Given this list of marker genes PSMC6, AKT3, HDAC3, MIR17, PSMB6, MIR26A1, CSNK2A1, MIR19B2, PSMD14, TNKS2, LAMTOR4, PSMA2 (NCBI Gene Id 5683), MIR22, MTA1, EGR1, MAPK1, HDAC1, PSMD3, PSMC1, CHD3, CBX8 (NCBI Gene Id 63441), PSMB3, RRAGB, GATAD2B (GATA zinc finger domain containing 2B), USP13, JUN, MECOM, TNRC6B, RBBP7, CSNK2B, PSMA4, PSMB7, PSMB2, PSMA1, BMI1, PSMB5, PSMD12, AGO4, PHC1 (NCBI Gene Id 283368), CBX4, PSMA7, RBBP4, PPARG, LAMTOR1, PHC3, CSNK2A2, WWP2, MTOR, CBX6, PSMA3, MIR19B1, TP53, MKRN1, MIR25, AGO1, XIAP, SEM1, PSMA6 (proteasome 20S subunit alpha 6), MOV10 (NCBI Gene Id 57723), MIR106B, UBB, TNKS, ATN1, PSMC2, MIR214, RPTOR, MTA2, PSMA5, PSMD13, SLC38A9, AGO3, STUB1, PML, PSMD7, ATF2, EED, SALL4, PSMC5, MIR93, USP7, GATAD2A, PSMD2, CHD4, MLST8, SCMH1, PREX2 (phosphatidylinositol-3,4,5-trisphosphate dependent Rac exchange factor 2), PSMD6, RHEB, PTENP1, MBD3, REST, MTA3, MAF1, NEDD4, NR2E1, LAMTOR5, SUZ12, SNAI2, MIR106A, HDAC5, PSMC3, MIR20A, TNRC6A, PSMB1, LAMTOR3, TRIM27, AGO2, VAPA, RNF2, AKT1, MIR20B, RRAGD, FRK, AKT2, CNOT6L, RING1, PSMB4, PSMD8, CBX2, MIR19A, PSMC4, UBC, RRAGC, PHC2, ADRM1, RCOR1, TNRC6C, LAMTOR2, MIR26A2, MIR205, MIR21, EZH2, MAPK3, RPS27A, PSMD1, RNF146, PTEN, OTUD3, PSMD11, UBA52, HDAC2, RRAGA, KDM1A, SNAI1, HDAC7, here is a description of the gene set: PTEN is regulated at the level of gene transcription, mRNA translation, localization and protein stability.<p>Transcription of the PTEN gene is regulated at multiple levels. Epigenetic repression involves the recruitment of Mi-2/NuRD upon SALL4 binding to the PTEN promoter or EVI1-mediated recruitment of the polycomb repressor complex (PRC) to the PTEN promoter. Transcriptional regulation is also elicited by negative regulators, including NR2E1:ATN1 (atrophin-1) complex, JUN (c-Jun), SNAIL and SLUG and positive regulators such as TP53 (p53), MAF1, ATF2, EGR1 or PPARG.<p>MicroRNAs miR-26A1, miR-26A2, miR-22, miR-25, miR-302, miR-214, miR-17-5p, miR-19 and miR-205 bind PTEN mRNA and inhibit its translation into protein. These microRNAs are altered in cancer and can account for changes in PTEN levels. In addition, coding and non-coding RNAs can prevent microRNAs from binding to PTEN mRNA. These RNAs are termed competing endogenous RNAs or ceRNAs. Transcripts of the pseudogene PTENP1 and mRNAs transcribed from SERINC1, VAPA and CNOT6L genes exhibit this activity (Poliseno, Salmena, Zhang et al. 2010, Tay et al. 2011, Tay et al. 2014).<p>PTEN can translocate from the cytosol to the nucleus after undergoing monoubiquitination. PTEN's ability to localize to the nucleus contributes to its tumor suppressive role. The ubiquitin protease USP7 (HAUSP) targets monoubiquitinated PTEN in the nucleus, resulting in PTEN deubiquitination and nuclear exclusion. PML, via an unknown mechanism that involves USP7- and PML-interacting protein DAXX, inhibits USP7-mediated deubiquitination of PTEN, thus promoting PTEN nuclear localization. Disruption of PML function in acute promyelocytic leukemia, through a chromosomal translocation that results in expression of a fusion protein PML-RARA, leads to aberrant PTEN localization.<p>Several ubiquitin ligases, including NEDD4, WWP2, STUB1 (CHIP), RNF146, XIAP and MKRN1, polyubiquitinate PTEN and target it for proteasome-mediated degradation. The ubiquitin proteases USP13 and OTUD3, frequently down-regulated in breast cancer, remove polyubiquitin chains from PTEN, thus preventing its degradation and increasing its half-life. The catalytic activity of PTEN is negatively regulated by PREX2 binding and TRIM27-mediated ubiquitination, most likely through altered PTEN conformation.<p>In addition to ubiquitination, PTEN also undergoes SUMOylation. SUMOylation of the C2 domain of PTEN may regulate PTEN association with the plasma membrane as well as nuclear localization of PTEN. PIASx-alpha, a splicing isorom of E3 SUMO-protein ligase PIAS2 has been implicated in PTEN SUMOylation. SUMOylation of PTEN may be regulated by activated AKT. Reactions describing PTEN SUMOylation will be annotated when mechanistic details become available.<p>Phosphorylation affects the stability and activity of PTEN. FRK tyrosine kinase (RAK) phosphorylates PTEN on tyrosine residue Y336, which increases PTEN half-life by inhibiting NEDD4-mediated polyubiquitination and subsequent degradation of PTEN. FRK-mediated phosphorylation also increases PTEN enzymatic activity. Casein kinase II (CK2) constitutively phosphorylates the C-terminal tail of PTEN on serine and threonine residues S370, S380, T382, T383 and S385. CK2-mediated phosphorylation increases PTEN protein stability but results in ~30% reduction in PTEN lipid phosphatase activity.<p>PTEN localization and activity are affected by acetylation of its lysine residues. PTEN can undergo oxidation, which affects its function, but the mechanism is poorly understood. Reactome Pathway: PTEN Regulation part of: PIP3 activates AKT signaling studied in species Homo sapiens